The following is a description of a gene set: studied in species Homo sapiens from publication Chen Y, Wang X (PMID 31504780) Human Gene Set: MIR4777_5P Genes predicted to be targets of miRBase v22 microRNA hsa-miR-4777-5p in miRDB v6.0 with MirTarget v4 prediction scores > 80 (high confidence targets)., and this is the list of marker genes: CCR9, VTCN1, TMEM50B, GYS2, CFAP119, DAZ3, NIPSNAP3B, KBTBD2, SEMA6D, ZNF644, FMO2, RAD9B, RDH10, FAM199X, CHMP1B (charged multivesicular body protein 1B), RORA, FBXO3, PIK3CG, ELOVL6, TADA1, SCML2, IFT80, XAF1, LILRA1, NDFIP1, UGT2A1, NAA50, EMC1, FOXO3, WDFY3, TMEM161B, ACADSB, NMT2, MCUR1, STK31, OR12D3, DAZ1, C4BPA, PLCB3, MAP4, SEPTIN2, TET3, C14orf93, VDAC1, JCAD, ZBTB8B, ZBTB2, G3BP1, MED4, KLF10, PPP1R12A, RAB14, ABRA, DIP2A, CPPED1, STYK1, PCLO, KLF15, CHRDL1 (NCBI Gene Id 91851), SIGLEC8 (NCBI Gene Id 27181), SRP14, NXPE3, SPTBN1, TTC39B, C1orf185, GFI1, PLAAT5, PAFAH1B1 (platelet activating factor acetylhydrolase 1b regulatory subunit 1), MMUT, MIPOL1, CFLAR, ENY2, NEGR1, PGGT1B, GNAI2, ENPEP, PRRC2C, PRPF38B, APOL6, BEND4, UGT2A2, CACNA1D, TMEM123, HIF3A, TMEM168, DNAAF11, RMDN3, KCNN3, SP100, SUZ12, CCDC172, GIPC3 (GIPC PDZ domain containing family member 3), PPP4R3B, MYNN, COG6, NIPSNAP3A, SCEL, TMED5, CREBRF, PHYH, ZNF80, SMIM15, KCNJ14, PDE12, RAD51AP2 (NCBI Gene Id 731721), CYGB, GPAM, UBE2D1, DAZ2, GLCE, DCAF10, CNOT4 (CCR4-NOT transcription complex subunit 4), DAZ4, CYCS, SLC1A3